Given this list of marker genes INTS6-AS1, SLX1B, UBE2Q1-AS1, TMEM156, IL2RB, SH3RF3, LRRC70, here is a description of the gene set: Genes up-regulated in myeloid dendritic cell 3d vs 0d in adults after exposure to 2011-2012 trivalent inactivated vaccine (A/California/7/09 (H1N1), A/Perth /16/2009 (H3N2), B/Brisbane/60/2008), time point 3D. Comment: Up-regulated DE RNA transcripts (up >= 1.5x) shared between both TIV-vaccinated donors species: Homo sapiens Systems biology is an approach to comprehensively study complex interactions within a biological system. Most published systems vaccinology studies have utilized whole blood or peripheral blood mononuclear cells (PBMC) to monitor the immune response after vaccination. Because human blood is comprised of multiple hematopoietic cell types, the potential for masking responses of under-represented cell populations is increased when analyzing whole blood or PBMC. To investigate the contribution of individual cell types to the immune response after vaccination, we established a rapid and efficient method to purify human T and B cells, natural killer (NK) cells, myeloid dendritic cells (mDC), monocytes, and neutrophils from fresh venous blood. Purified cells were fractionated and processed in a single day. RNA-Seq and quantitative shotgun proteomics were performed to determine expression profiles for each cell type prior to and after inactivated seasonal influenza vaccination. Our results show that transcriptomic and proteomic profiles generated from purified immune cells differ significantly from PBMC. Differential expression analysis for each immune cell type also shows unique transcriptomic and proteomic expression profiles as well as changing biological networks at early time points after vaccination. This cell type-specific information provides a more comprehensive approach to monitor vaccine responses. from publication Hoek KL, Samir P, Howard LM, Niu X, Prasad N, Galassie A, Liu Q, Allos TM, Floyd KA, Guo Y, Shyr Y, Levy SE, Joyce S, Edwards KM, Link AJ (PMID 25706537) Human Gene Set: HOEK_MYELOID_DENDRITIC_CELL_2011_2012_TIV_ADULT_3DY_UP